Given this list of marker genes WNT2, CSNK2A1, TCF7L2, SHC3, RPS6KB1, BAX, AKT1, FRAT1, WNT16, FGF6, CSNK2B, HEY2, FGF22 (fibroblast growth factor 22), HES1, GADD45G (NCBI Gene Id 23575), PIK3CD, MAPK1, ATR, APC, WNT10A, SHC1, DLL3, PARP1, MAPK3, FZD8, JUN, LRP5, AKT2, FZD3, RB1 (RB transcriptional corepressor 1), FGF5, MRE11, PIK3R3 (NCBI Gene Id 8503), APC2, CTNNB1, WNT6, HRAS, ATM, ESR1, SHC4, FGF18, WNT7B, FGF2 (fibroblast growth factor 2), NBN, DLL1, WNT3, TCF7L1, WNT1, NFKB2, WNT7A, SFRP4, GSK3B, WNT10B, CCND1, DDB2, MYC, WNT3A, POLK, GADD45A (NCBI Gene Id 1647), IGF1R, RAF1, FGF23, E2F2, FZD6, SKP1, RPS6KB2, IGF1, CSNK2A3, FGF1, NOTCH2, WNT11, EGFR, FZD1, CDK6, FGF10, FGFR1, CETN3, WNT2B, FGF9 (fibroblast growth factor 9), ERBB2, RAD51, HEYL, E2F3, WNT5B, TP53, FGF17, PIK3CA, FZD7, SOS2, BAK1, TCF7, FZD5, FZD9, SP1, PIK3R2, TNFSF11, CSNK2A2, BRAF, FOS, ESR2, PTEN, MAP2K2, E2F1 (E2F transcription factor 1), GADD45B, DVL1, BRCA1, HES5, FLT4, LEF1 (lymphoid enhancer binding factor 1), CSNK1A1, NOTCH1, FZD2, HEY1, PGR (progesterone receptor), AKT3, AXIN2, KIT, NOTCH4, CDK4, FGF3, PIK3R1, WNT4, AXIN1, NCOA1, CDKN1A, NCOA3, FGF16, NOTCH3, FGF8, DLL4, MTOR, DVL3, JAG2, FGF20, LRP6, GRB2, SOS1, RAD50 (RAD50 double strand break repair protein), EGF, DVL2 (dishevelled segment polarity protein 2), NRAS, SHC2, FGF7, WNT5A, FRAT2, FGF19, ARAF, FGF4, FZD10, CSNK1A1L, BRCA2, KRAS, MAP2K1, FGF21, here is a description of the gene set: Human Gene Set: WP_BREAST_CANCER_PATHWAY Breast cancer pathway species: Homo sapiens